Given this list of marker genes JUNB, GGNBP2, RBPJ, NSDHL, OVOL2, MAPK1, HS6ST1, FZD5, AKT1, VASH1, HEY1, LLGL2, VASH2, FBXW8, HEY2, WNT2, PLG, PLCD3, HES1, CCN1, TMED2, here is a description of the gene set: studied in species Homo sapiens The process whose specific outcome is the progression of a blood vessel of the labyrinthine layer of the placenta over time, from its formation to the mature structure. The embryonic vessels grow through the layer to come in close contact with the maternal blood supply. Human Gene Set: GOBP_LABYRINTHINE_LAYER_BLOOD_VESSEL_DEVELOPMENT